The following is a description of a gene set: studied in species Homo sapiens Abnormality of facial musculature An anomaly of a muscle that is innervated by the facial nerve (the seventh cranial nerve). Human Gene Set: HP_ABNORMALITY_OF_FACIAL_MUSCULATURE, and this is the list of marker genes: GJA1, CACNA1S, SNCA, ACADS, REV3L, SYT2, POMT2, SCN1A, TGFB1, CAMK2G, SNX10, TUBB3, ITGB4, DNMT3B (DNA methyltransferase 3 beta), AP4S1, GIPC1, AP4B1, ITGA7, DCTN1, PIK3CA, ALG14, UBA2, ATP1A3, GPC4, ACTN2, FRG1, MT-CO3, TPM2, PRDX3, SLC1A3, CLTC, MEGF10, DNAJC6, DDHD2, PABPN1, VCP, PPP2R5D, AK9, POU3F3, KLHL40, TCIRG1, SLC25A1, ATXN1, RRM1, DNM1L, ATCAY (NCBI Gene Id 85300), GBA1, SNUPN, CRLF1 (NCBI Gene Id 9244), SLC39A14, SLC30A10, PLAA, SLC30A9, DUX4L1, CHAT, DOK7, GLE1, SLC19A3, LGI3, ACTA1, SUFU, BMS1, NUTM2B-AS1, SYNE1, FLNC, YARS1, MYH7 (NCBI Gene Id 8090), DPAGT1, CC2D1A, KDM4B, GDAP1, ADA2, NEB, PCGF2, SPTBN2, MSTO1, EBF3, ASAH1, AMPD2, NOD2, COL13A1, ITPR1, NOTCH2NLC, AP4M1, MT-CO1, SMARCE1 (NCBI Gene Id 6605), CACNA1A, TPM3, VPS35, PLA2G6, XYLT2, POMT1, TREX1, ZMIZ1, OBSCN, CNTNAP1, ALG2, HLA-DRB1, SIX1, PEX5, DNAJC13, CHRNA1, VPS13B, PEX3, PODXL, MECP2, PEX6, SEMA3E, PLXND1, TERT, SLC25A21, MUSK, TRIM32, DUX4, FBXO7, NGLY1, FKTN, BICRA, LRP4, RYR1, GJC2, MAN2B1, TFAP2A, COL12A1, KY, POLG2, DBH, LRP12, COL6A2, PLEC, SALL4, TXNL4A, KDM5C, PEX10, SQSTM1, SET, TECPR2, PUF60, RAB11B, ANO5, CHD7, SPEG (striated muscle enriched protein kinase), CLCF1, TOR1A, AGRN, SYNJ1 (synaptojanin 1), GRIA3, CHAMP1, PRRT2, CADM3, PAX7, CNBP, MYPN, MT-TE, TTN, UNC80, MGME1, PEX13, PPP2R1A, TNFSF11, STAG2, GAN, DNM2 (NCBI Gene Id 338330), PEX11B, LMOD3, PNPT1, ATP13A2, SCN4A, MYOT, EIF4G1, SUCLA2, MB, NFU1, ZC4H2, AP4E1, SLC12A6, CRPPA, LRP5, MTM1, KCNK9, EYA1, GPC3, SUPT16H, FTL, LAMB2, PI4KA, SHMT2, ATP6AP2, MYMK, SMO, GAA, COL6A1, TNNT1, MT-TN (mitochondrially encoded tRNA-Asn (AAU/C)), YY1, DMPK, COL4A1, CRYAB, ABCA1, OSTM1, KBTBD13, TRPV4, COLQ, SURF1, UBE2T, SGCD, ADSS1, SNAP25, OPA1, PPP2R2B, RYR3, KLHL41, DLL4, CHRNE, JAM2, PURA, POLG, SOST, TET3, STRADA, FKRP, RRM2B, HOXB1, ANTXR1, SLC25A42, DES, PTRH2, MYL1, SH3TC2, ADCY5, SLC18A2, DSE (NCBI Gene Id 29940), PTDSS1, ZBTB11, SLC25A4, KIF1B, HK1 (NCBI Gene Id 59333), XRCC2, GMPPB, SMARCB1, SLC52A2, CHRNB1, GSN, ALS2, NF2, VAMP1, HERC1, AMER1, BAP1, SMCHD1, MTMR2, CAPN3, POGZ, DYNC1H1, PRKCG, LAMA2, RAPSN, CHRNG, CFL2, BTNL2, SPTBN4, KMT2D (NCBI Gene Id 8085), MSX1, MPZ, STAC3, COX6A2, SF3B2, PEX19, CHRND, CLCN7, SRRM2, GIGYF2, ATP1A2, SLC5A7, CHKB, IRF2BPL, SPR, RNASEH1 (NCBI Gene Id 246243), ABCD1, GFPT1, LRRK2, NEFL, SATB2, CHCHD10, ADGRG1, SIX5, ANXA11, TUBB6, BAG3, PDGFB, SLC6A3, PEX2 (peroxisomal biogenesis factor 2), ANKH, LPIN1, PEX16, ADNP, RILPL1, AKT1, TP63, PEX26, TK2, SLC18A3, PEX1, NARS2, TRAF7, SBF2, MTRFR, SLC52A3, HACD1 (3-hydroxyacyl-CoA dehydratase 1), SRPX2, NECTIN1, PEX12, BIN1, MYMX, ASXL1, ADCY6, UBA1, LRIF1, SELENON, MAP3K20, MTMR14, RNU4-2, TWNK, PEX14, SCO2, JAG2, MYL2, KCNK4, YME1L1, DNAJB6, TNNC2, MYO9A, GNE, LARGE1, IRF6